The following is a description of a gene set: Genes down-regulated in dendritic cell 1d vs 0d in adults (18-49) after exposure to inactivated monovalent influenza A/Indonesia/05/2005 H5N1 split-virus vaccine, time point 1D, administered i.m. from publication Howard LM, Hoek KL, Goll JB, Samir P, Galassie A, Allos TM, Niu X, Gordy LE, Creech CB, Prasad N, Jensen TL, Hill H, Levy SE, Joyce S, Link AJ, Edwards KM (PMID 28099485) studied in species Homo sapiens Human Gene Set: HOWARD_DENDRITIC_CELL_INACT_MONOV_INFLUENZA_A_INDONESIA_05_2005_H5N1_AGE_18_49YO_1DY_DN BACKGROUND: Vaccine development for influenza A/H5N1 is an important public health priority, but H5N1 vaccines are less immunogenic than seasonal influenza vaccines. Adjuvant System 03 (AS03) markedly enhances immune responses to H5N1 vaccine antigens, but the underlying molecular mechanisms are incompletely understood. OBJECTIVE: We compared the safety (primary endpoint), immunogenicity (secondary), gene expression (tertiary) and cytokine responses (exploratory) between AS03-adjuvanted and unadjuvanted inactivated split-virus H5N1 influenza vaccines. In a double-blinded clinical trial, we randomized twenty adults aged 18-49 to receive two doses of either AS03-adjuvanted (n = 10) or unadjuvanted (n = 10) H5N1 vaccine 28 days apart. We used a systems biology approach to characterize and correlate changes in serum cytokines, antibody titers, and gene expression levels in six immune cell types at 1, 3, 7, and 28 days after the first vaccination. RESULTS: Both vaccines were well-tolerated. Nine of 10 subjects in the adjuvanted group and 0/10 in the unadjuvanted group exhibited seroprotection (hemagglutination inhibition antibody titer > 1:40) at day 56. Within 24 hours of AS03-adjuvanted vaccination, increased serum levels of IL-6 and IP-10 were noted. Interferon signaling and antigen processing and presentation-related gene responses were induced in dendritic cells, monocytes, and neutrophils. Upregulation of MHC class II antigen presentation-related genes was seen in neutrophils. Three days after AS03-adjuvanted vaccine, upregulation of genes involved in cell cycle and division was detected in NK cells and correlated with serum levels of IP-10. Early upregulation of interferon signaling-related genes was also found to predict seroprotection 56 days after first vaccination. CONCLUSIONS: Using this cell-based systems approach, novel mechanisms of action for AS03-adjuvanted pandemic influenza vaccination were observed. TRIAL: ClinicalTrials.gov NCT01573312., and this is the list of marker genes: FCRL5, CEBPA, PTGDR2, FOXO6, SLC28A3, IL1R2, PITPNM2, FIBCD1, ZNF704, CBX2, NOTCH3, GPRC5B, PPP1R3G, ANGPT1, LRP3, MAP2K6, BMERB1, MIR4771-1, IGFBP6, MYO10, PDGFC, ZNF443, CDK5R1, PRPF31 (NCBI Gene Id 6106), RANBP17, OLIG1, TNNT3, SLC5A10 (NCBI Gene Id 125206), TBATA, ACY3, RPH3A, ADGRD1, RASL10A, MN1, SMAD6, CSGALNACT1, SOX12, CES3, IL1R1, FAM167A, LKAAEAR1